Given this list of marker genes USP16 (ubiquitin specific peptidase 16), SMYD5, EIF5AL1, EIF5A2, EIF5A, here is a description of the gene set: Human Gene Set: GOBP_POSITIVE_REGULATION_OF_TRANSLATIONAL_ELONGATION species: Homo sapiens Any process that activates or increases the frequency, rate or extent of translational elongation.